The following is a description of a gene set: from publication Chen Y, Wang X (PMID 31504780) Genes predicted to be targets of miRBase v22 microRNA hsa-miR-1238-5p, hsa-miR-4758-5p in miRDB v6.0 with MirTarget v4 prediction scores > 80 (high confidence targets). studied in species Homo sapiens Human Gene Set: MIR1238_5P_MIR4758_5P, and this is the list of marker genes: FOXL2NB, GLRX, SLC2A1, SEC31A, CSNK1E, TXNDC8, NXPH1, ZDHHC3, AP1G1, LCE2D, GTF2H5 (general transcription factor IIH subunit 5), MXRA7 (NCBI Gene Id 54588), GFPT1, TUBGCP4, KIAA0040, ADO, VDAC1, GSG1L, RBM39, TPTEP2-CSNK1E, IRF6, TANC2, SUGP2, PLD1, CREB1, NDUFV3, UBASH3B, STMN2, PPME1, CCP110, SAXO1 (stabilizer of axonemal microtubules 1), GDF6, DNAJB5, CNOT6L, GRK5, B4GALNT1, UBE2A, PRELID1, TBC1D12, ZNF334, PRR14L, CLCN6, CREB3L1, ZNF652, SOAT1